Given this list of marker genes F12, CPN1, KNG1, BDKRB1, BDKRB2, SERPING1, KLKB1, here is a description of the gene set: Human Gene Set: WP_KININKALLIKREIN_PATHWAY species: Homo sapiens Kinin-Kallikrein pathway